Given this list of marker genes ACVR2B, AMMECR1L, SLC37A4, MCU, AKIRIN2, CDK16, KCNK3, ASIC2, TLNRD1, NR2E1, FMNL1, IGF2BP3, WNK1, SRRM3, MYH10 (myosin heavy chain 10), TFAP2C, SALL1, TSEN2, PABPC1 (poly(A) binding protein cytoplasmic 1), GPBP1, HOXA1, RAPGEFL1 (Rap guanine nucleotide exchange factor like 1), FKBP14, NAT8L, RAD21 (NCBI Gene Id 5885), NUFIP2, ARAP1 (NCBI Gene Id 23290), FASTK, ERF, MGAT4B, SLC18A3, SLC7A10, HDLBP, RFX1, FGF9, FOXA3, ASCL1, MIB1, ARID1A, WNK4, CYTH2, LRFN5, SAMTOR, TMEM25, PTK7, CGREF1, ATP5PD, VEGFA, FBRS, TSSK3, SMARCD1, KCNJ12, SLC17A7, PICALM, NTF4, MLLT6, EYA1, VWCE, KCNH5, APLP1, ARF3, ZNF362, ANP32A, CDC73, SYT7, BCAT2, OSR2, SIPA1, ITPKA (inositol-trisphosphate 3-kinase A), CRY1, CAMKV, TFAP4, SOBP, MSTN, SLC25A28, RNF220, SPATA6 (spermatogenesis associated 6), HAPSTR1, TMEM256, UNC79, CD248, RALYL, CYB561D1, LCOR, SCUBE3, KIF3C, C6orf62, EPHB1, PAQR4, KLF13, STARD13, UBTF (upstream binding transcription factor), DGCR8, RAP1GDS1, TFEB, PDGFB, POU5F1, MAFB, HOXB2, KCNQ4, FNBP1, TACC2, SPRED1, PPP2R5A, MAP1B, NCOA6, TRIM39, BCOR, PGF, GRK6, BCL6, PABPC4, GLTP, PLEKHA8, NR2F2, TGS1, MKNK2, ARHGAP36, EIF4G2, HPN, PKN1, ENHO, KLF10, TRMT1, RPL36AL, KCNH8, TERF2, NFYC, DMPK, RDH10, DBN1, KDM3B, RBM6, NCOA2, PPP6R2, OAZ2, SLC12A4, EGR3, DLG3, KMT2E, GNG8 (NCBI Gene Id 94235), NIPBL (NIPBL cohesin loading factor), MIR17HG, KDM2A, PORCN, LHX2, SOX2, TLK2, VPS25, CEND1, CIC, TMEM132E, ZNF703 (NCBI Gene Id 80139), CHD4, MN1, SLC6A11, PTMA, SMIM29, CCNG1, CPEB3, FGF11, CIRBP, MED26, ZMYM2, TMEM59L, NIBAN1, ADIPOR1, CADM1, ST8SIA2, LRRC8D, CXXC5, PLCB3, CELSR2, ANGPTL2, PPM1E, GGNBP2 (gametogenetin binding protein 2), RASIP1, ZNF281, CLDN5, COL12A1, FAM89B, HOXB9, DYNC1LI1, PRDM16, MARCKSL1, BAHD1, OTUD7B, ST7, GPR12, SYMPK, PLXNC1, PFKFB3, OGA, B4GALT1, TRIM28, GP1BB, RGMA, MGAT2, RHBDF1, PCGF1, FXYD1, PIAS1, DTWD2, MARCHF5, EFNB3, AGAP1, JADE2, RNF40, CREBRF, UBE2S, CDK9, SH3BP4, DLGAP4, MED13, CERCAM, WNT5A, IL11, EIF1, CIRBP-AS1, KCNH2, TMEM68, POFUT1, ADRB1, MTCH2, DTNB, FGD1, RAB35, USP49, ABHD17AP5 (ABHD17A pseudogene 5), CNP, KCNAB3, CHAT, ANKRD40, NRF1, TEX2, IGF2BP1 (insulin like growth factor 2 mRNA binding protein 1), ZNRF2, RASGRP2, CLASRP, SMAD7, TAB2, FAM219A, PHF1, ALG10, LDB1, STMN1, PIANP, PLAGL2, CNNM4, TNFAIP8L3, ASS1, FAM53C, DNMT3A, CAMTA2, HEY1, SPACA6, NXPH3, NYAP1, CPSF4, PCIF1, FAM76A, PIP4K2B, ADAMTS5, ZNF516-DT, CTCF, NACC1, NEO1, DNAI1, ZBTB7A, LHFPL4, GPR3, here is a description of the gene set: studied in species Homo sapiens Human Gene Set: AP2_Q6_01 Genes having at least one occurrence of the motif SNNNCCNCAGGCN in the regions spanning 4 kb centered on their transcription starting sites. This matches the GTF3A transcription factor binding site V$AP2_Q6_01 (v7.4 TRANSFAC).